The following is a description of a gene set: Troglitazone (TGZ), a member of the thiazolidinedione class of anti-diabetic compounds and a peroxisome proliferator activator receptor-gamma (PPAR-gamma) agonist, restores systemic insulin sensitivity and improves the full insulin resistance syndrome in vivo. The mechanisms underlying its in vivo function are not understood. Here we investigated the potential functional interaction between PPAR-gamma and NF-kappaB in adipocytes. We show that TGZ selectively blocked tumor necrosis factor-alpha-induced and NF-kappaB-dependent repression of multiple adipocyte-specific genes and induction of growth phase and other genes. This occurs without interfering with NF-kappaB expression, activation, nuclear translocation, or DNA binding and without suppressing NF-kappaB-dependent survival signals. Notably, the expressions of some tumor necrosis factor-alpha-induced genes in adipocytes were unaffected by PPAR-gamma activation. In reporter gene assays in HeLa cells, ectopic expression of PPAR-gamma abolished induction of a NF-kappaB-responsive reporter gene by the p65 subunit (RelA) of NF-kappaB, and the inhibition was further enhanced in the presence of TGZ. Conversely, overexpression of p65 inhibited induction of a PPAR-gamma-responsive reporter gene by activated PPAR-gamma in a dose-dependent manner. The inhibitory effect was independent of the presence of NF-kappaB-binding sites in the promoter region. Other NF-kappaB family members, p50 and c-Rel as well as the S276A mutant of p65, blocked PPAR-gamma-mediated gene transcription less effectively. Thus, p65 antagonizes the transcriptional regulatory activity of PPAR-gamma in adipocytes, and PPAR-gamma activation can at least partially override the inhibitory effects of p65 on the expression of key adipocyte genes. Our data suggest that inhibition of NF-kappaB activity is a mechanism by which PPAR-gamma agonists improve insulin sensitivity in vivo and that adipocyte NF-kappaB is a potential therapeutic target for obesity-linked type 2 diabetes. from publication Ruan H, Pownall HJ, Lodish HF (PMID 12732648) Human Gene Set: RUAN_RESPONSE_TO_TROGLITAZONE_DN studied in species Mus musculus Adipocyte abundant genes down-regulated in 3T3-L1 cells (fibroblasts induced to differentiate to adipocytes) in response to troglitazone., and this is the list of marker genes: PLA2G6, IRX3, CDKN2C, PPARG, IDH3G, ADIPOQ, SELENBP1, AOC3, AP3S1, RGS2, ORM1 (NCBI Gene Id 5004), HK2, TST, THRSP, AK2, NRIP1, HLA-B